Given this list of marker genes UQCC5, COX17, BCS1L, MT-CO3, TIMM21, COA1, COA6, COA5, COX18, FASTKD3, SCO1, TMEM223, COA3, CEP89, COX19, SLC25A46, PET100, UQCC6, COA7, COX10, COA4, SMIM20, TACO1, COX14, COX20, COA8, SURF1, STMP1, COX16, PET117, SCO2, here is a description of the gene set: The aggregation, arrangement and bonding together of a set of components to form respiratory chain complex IV (also known as cytochrome c oxidase), the terminal member of the respiratory chain of the mitochondrion and some aerobic bacteria. Cytochrome c oxidases are multi-subunit enzymes containing from 13 subunits in the mammalian mitochondrial form to 3-4 subunits in the bacterial forms. studied in species Homo sapiens Human Gene Set: GOBP_RESPIRATORY_CHAIN_COMPLEX_IV_ASSEMBLY